The following is a description of a gene set: Processing of SMDT1 species: Homo sapiens Human Gene Set: REACTOME_PROCESSING_OF_SMDT1, and this is the list of marker genes: MCU, PMPCB, MICU1, STOML2, PMPCA, MICU2, SPG7, SMDT1, AFG3L2, PARL, MAIP1, YME1L1, PHB1, PHB2, MICU3, MCUB